The following is a description of a gene set: Mouse Gene Set: GOCC_SPECTRIN_ASSOCIATED_CYTOSKELETON species: Mus musculus The part of the cytoskeleton composed of spectrin, protein 4.1 and ankyrin. Spectrin-associated cytoskeleton is associated with the plasma membrane., and this is the list of marker genes: Ank3, Dmtn, Sptb, Sptbn2, Ank1, Spta1, Rhbg